Given this list of marker genes ALOX5AP, LCP1 (lymphocyte cytosolic protein 1), LIN7A, ACOT7, NFE2, PRG2, PSME3IP1, FNBP1, RNASE3, PLAC8, AZU1, TRGC2, NUCB2, ATP2B4, CTSG, CMTM3, ATG16L2, SAMSN1, GCA, PTGER4, SLA, ITM2C, CSF3R, NKG7 (natural killer cell granule protein 7), MS4A3, SRGN, IGFBP7, CXCR4, CAT, SELPLG, PRRC2C (NCBI Gene Id 23215), PSTPIP1, ICAM3, LYZ, C11orf21, MYO1F, BTG1, IL6R, HSPA6, CD24, LST1, RASGRP2, CEACAM6, CST7, OS9, SPCS3, RNASE2, BPI (NCBI Gene Id 671), LAPTM5, CD302, S100A8, ALDH3B1, ARL15, here is a description of the gene set: The chromosomal translocation t(8;21) is associated with 10-15% of all cases of acute myeloid leukaemia (AML). The resultant fusion protein AML1/MTG8 interferes with haematopoietic gene expression and is an important regulator of leukaemogenesis. We studied the effects of small interfering RNA (siRNA)-mediated AML1/MTG8 depletion on global gene expression in t(8;21)-positive leukaemic cell lines and in primary AML blasts using cDNA arrays, oligonucleotide arrays and real-time reverse transcription-polymerase chain reaction (RT-PCR). Suppression of AML1/MTG8 results in the increased expression of genes associated with myeloid differentiation, such as AZU1, BPI, CTSG, LYZ and RNASE2 as well as of antiproliferative genes such as IGFBP7, MS4A3 and SLA both in blasts and in cell lines. Furthermore, expression levels of several genes affiliated with drug resistance or indicative of poor prognosis AML (BAALC, CD34, PRG2, TSPAN7) are affected by AML1/MTG8 depletion. In conclusion, siRNA-mediated suppression of AML1/MTG8 cause very similar changes in gene expression pattern in t(8;21)-positive cell lines and in primary AML blasts. Furthermore, the results suggest that the specific targeting of AML1/MTG8 function may be a promising approach for complementing existing treatment strategies. Human Gene Set: DUNNE_TARGETS_OF_AML1_MTG8_FUSION_UP Genes up-regulated in Kasumi-1 cells (acute myeloid leukaemia (AML) with the t(8;21) translocation) after knockdown of the AML1 MTG8 fusion by RNAi. from publication Dunne J, Cullmann C, Ritter M, Soria NM, Drescher B, Debernardi S, Skoulakis S, Hartmann O, Krause M, Krauter J, Neubauer A, Young BD, Heidenreich O (PMID 16652140) species: Homo sapiens